The following is a description of a gene set: Mouse Gene Set: GOBP_MODULATION_OF_PROCESS_OF_ANOTHER_ORGANISM species: Mus musculus A process in which an organism effects a change in a biological process in another organism., and this is the list of marker genes: Tmeff1, Hmga2, Cxcl5, Snx3, Card9, Cdk9, Brd4, Nucks1, Trim31, Trim11, Lrrc15, Fmr1, Hdac1, Pik3c2g, Prf1, Rock2, S100a9, Trim56, Ifitm6, Vapb, Zdhhc20, Zfyve1, Eea1, Trim12a, Fbln1, Fasn, Trim30a, Trim30b, Hpn, Ccnk, Tmem41b, Tardbp, Cd74, Ltf, Camp, Pik3c3, St6galnac1, Bcl2l11, Clec7a, Fcer2a, Trim25, Trim5, Fbxl2, Zc3h12a, Cdc42, Smarcb1, Lef1, Taf11, Muc2, Rad50, Becn1, Snw1, Inpp5k, Rrp1b, Zfp639, Cx3cr1, Mid2, Chd1, Ddx56, Eif2ak4, Apcs, Trim30d, Hspa8, Gsn, Zdhhc9, Zdhhc8, Nod2, Rab5a, Arg1, Igf2r, Lrrc19, Trim59, Pi4ka, Ly6e, Nlrp6, Csf1r, Galp, Napepld, Trim8, Smc6, Vapa, Pou2f3, Nbn, Cfl1, Rest, Pcx, Ifitm2, Slpi, Mre11a, Tbc1d20, Fcnb, Ptx3, Trim26, Ccnt1, Ythdc2, Stom, Ifitm3, Cav2, Ifitm7, Ccl5, Ccl3, Trim30c, Ccl8, Pomc, Bad (NCBI Gene Id 12015), Trim10, Jun, Ppib, Ifitm1, Eef1a1, Paip1, Rab29, Cxcl1, Ctdp1, Sprr2a1, Smc5, F2rl1, Akt1, Epg5, Trim12c, Ep300, Ppara, Ifng, Syk, Tfap4, Sp1, Apoe, Phb1, Smarca4, Prkn, Nos2, Ciita